The following is a description of a gene set: Human Gene Set: GSE43863_NAIVE_VS_MEMORY_TFH_CD4_TCELL_D150_LCMV_DN species: Homo sapiens from publication Hale JS, Youngblood B, Latner DR, Mohammed AU, Ye L, Akondy RS, Wu T, Iyer SS, Ahmed R (PMID 23583644) CD4 T follicular helper (Tfh) cells provide the required signals to B cells for germinal center reactions that are necessary for longlived antibody responses. However, it remains unclear whether there are CD4+ memory T cells committed to the Tfh lineage after antigen clearance. Using adoptive transfer of antigen-specific memory CD4+ subpopulations (based on CXCR5 and Ly6c expression)in the LCMV infection model, we found that there are distinct memory CD4+ T cell populations with commitment to the Tfh and Th1 lineages. Our conclusions are based on gene expression profiles, epigenetic studies and phenotypic and functional analysis. The gene expression profiles of virus-specific CD4 T cell subets at effector and memory stages is presented here. Genes down-regulated in CD4 SMARTA T cells: naïve versus memory follicular helper (Tfh)., and this is the list of marker genes: RSL24D1, RWDD4 (NCBI Gene Id 201965), ARFRP1, LMO4 (NCBI Gene Id 8543), ENTPD6, KTI12 (KTI12 chromatin associated homolog), IL6 (interleukin 6), BATF, EIF4A1, RCC1, MAT2A, RRP9, SELENOI, EIF4E, CTPS1, CEP83, CHST11, NOP9, HOXB1, HOMER1, FASTKD3, ETF1, SLC25A1, KCTD13, SRM, NLE1 (NCBI Gene Id 54475), ANKRD13B, PELP1, MIOS, GRHL1, BEX1, GTPBP4, ABT1, UMPS, TMA16, LAG3, RHBDL3, PTAR1, CFLAR, RCC1L, AGPAT5 (1-acylglycerol-3-phosphate O-acyltransferase 5), NOC3L, CST7, PDCD1LG2, AMZ1, SPOUT1, ST6GALNAC4, RAB34, FOXRED2, XCL1, SLC25A32, SEMA7A, FOSL1, EXOSC2, TLCD1, ARL4C, MTRR, RAPGEF5 (Rap guanine nucleotide exchange factor 5), SOX12, PRDM4, TMEM150A, WDR43, BAG2, ALOX15B, ALG2, CACYBP, BTG3, SLC19A2, CIART, PPAT, PSMD8, FTSJ3, CD44, ERH, IRF8, NAF1, IDH3A, SLC39A14, RPS6KA2, HPRT1, XXYLT1, IL2RA, IFRD2, ZC3H12C, UTP6, SLC25A33, LYAR, CCDC137, SOX21, SLC9A5, SPRYD7, APOO, TRIB1, PMP22, PITRM1, LARS1, MAN1A2, CHRNA2, RAP1B, PRPS1, HIC1, ERG28, PEDS1, CHCHD4, SCN1A, RUVBL2, PPP5C, DDX31, C7orf50, NFKBIB, MAK16, GRWD1, RAB20, TRNAU1AP, SRFBP1, THOP1, PREP, ATF3, RCN1, CLEC12B (NCBI Gene Id 387837, C-type lectin domain family 12 member B), EIF2B3, ZMYND19, WDR55, NUDT5, PLK3, TRMT6, POLR3D, NBN, PUS10, SLC16A1 (NCBI Gene Id 6566), CCNB1IP1, SLC7A1, WEE1, LIPG, FASN, RBPMS2, GFI1, IL15RA, PDGFC, AGFG1, DNMT3B, SLC35G1, DDX56, GJC3, B4GALT5, GSPT1, LAP3, RBM15B, SH2D2A, UTP4, NOL11, ERO1A, SLC5A6, URB2, ORC2, WDR77, EIF2S2, KLF16, ODC1, HILPDA, TIMM44, AIMP2, SYTL3, NUP205, RCL1, MAFG, SLC15A3, RUVBL1, MYO1E, PLXND1, SERPINB9, EGR2, USP36, IFNLR1, SLC7A6, HNF1B, HSPD1, DUSP4, RIOX1, NAA50, NOP16, SLC39A6, GLA, HMGA1, CITED2, EPOP, TBP, FRAS1, FABP5, DDX18, UAP1, ACTN1, MRTO4, MRPL50, PCGF6, TIMM8A, UBXN2A, WDR18, NUS1, ADM